The following is a description of a gene set: Mouse Gene Set: GOBP_PYRIMIDINE_CONTAINING_COMPOUND_METABOLIC_PROCESS The chemical reactions and pathways involving a pyrimidine-containing compound, i.e. any compound that contains pyrimidine or a formal derivative thereof. species: Mus musculus, and this is the list of marker genes: Uckl1, Nme1, Cdadc1, Cad, Stpg4, Crmp1 (NCBI Gene Id 12933), Dpysl3, Upp2, Nme6, Nme3, Pycr3, Dut, Tpk1, Thtpa, Tymp, Nme5, Dpysl4, Dhfr, Dhodh, Uck1, Cmpk1, Dctd, Uck2 (NCBI Gene Id 98564), Slc19a3, Nt5m, Entpd5, Nme4, Mtor, Nme2, Ak9, Nt5c3, Aicda, Dpysl2, Dpyd, Ctps1, Acp3, Upb1, Dpysl5, Dpys, Nt5c, Dtymk, Ctps2, Slc25a19, Entpd4, Uprt, Cda, Slc19a2, Shmt2, Dctpp1, Tyms, Tk2, Ak3, Upp1, Slc4a7, Entpd7, Tbpl1, Enpp3, Mapk1, Tk1 (NCBI Gene Id 21877), Aldh6a1, Rrm1, Shmt1, Cmpk2, Nme7, Entpd4b, Tet2, Cps1, Umps, Dck (deoxycytidine kinase)